The following is a description of a gene set: studied in species Homo sapiens Human Gene Set: MIR12128 from publication Chen Y, Wang X (PMID 31504780) Genes predicted to be targets of miRBase v22 microRNA hsa-miR-12128 in miRDB v6.0 with MirTarget v4 prediction scores > 80 (high confidence targets)., and this is the list of marker genes: GNG2, ACSL4, OCM2, CXCL9, SRL, COG4, METTL15, ANKRD50, TBC1D9B, L2HGDH (L-2-hydroxyglutarate dehydrogenase), RAB6B (NCBI Gene Id 51560), MX2, MCRIP1, CC2D2B, GYPC, RAPGEF1, DAAM1, ZC3H7B, CDIN1, GTF2H3, NSUN4, TSLP (thymic stromal lymphopoietin), KMT2D, SPRR2E, AUTS2, PABIR1, CNTN4 (NCBI Gene Id 53943), KRTAP5-10, MAP6D1, MYD88, AMMECR1L, SH3PXD2A, TAB2, SATB2, PDZD11 (PDZ domain containing 11), TMEM67, WIPF1, USP51, MEF2A, GLG1, PDZD7, GOLM2, VPS33B, RAD51B, DNAJB9, SPRR2B, TUSC1, GPALPP1, PRDM16, CIBAR1, ZNF114, KCNA1, ABHD2, GANC, FKBP9, SERPINB5, PAPOLB, CA8, TCAIM, PATE2 (prostate and testis expressed 2), ATP10D, OCM, TOPBP1, TMCO3, PRNP, CNOT6L, FAM78A, MOB1B, WDR91, LAMC1, ARHGAP12, STAG2, PPP1R13B, GFOD2, SPRR2A, CTC1, DCUN1D5, CRYM, KSR2, ARAP3, CROT, FZD4, ATP2C1, PERP, SPRR2D, IGF2R, LINC03040, INTS9, CYP2R1, KIAA1671 (KIAA1671), TMEM9, ADAMTS18, FEZF1, JAZF1, PSMC1, SERP1, C17orf50, OPHN1, ASF1A, PWWP3B (PWWP domain containing 3B), C19orf25, RBFOX2, CCL22, XK, OPALIN, RPH3AL, CLCC1, SENP5, LTA (lymphotoxin alpha), TET3, AUNIP, KRTAP4-2, YLPM1, CDH13, DCC, PDZD8, CLSPN, COL11A2, HTR3D, CRB2, CSNK2A1, MYLK4, TOX, FPGT, USP25, TPRX1, HOXA11, RNF115, CABP4, MUC7, PRICKLE1, SPRTN, TMBIM4, CCDC42, TMEM170B, ZC3H12C, MYL1, ZNF502, CNGA2, VCL, TOR2A, NCAM1, ZFAT (zinc finger and AT-hook domain containing), ZFX, ANK1